The following is a description of a gene set: species: Mus musculus Mechanisms regulating self-renewal and cell fate decisions in mammalian stem cells are poorly understood. We determined global gene expression profiles for mouse and human hematopoietic stem cells and other stages of the hematopoietic hierarchy. Murine and human hematopoietic stem cells share a number of expressed gene products, which define key conserved regulatory pathways in this developmental system. Moreover, in the mouse, a portion of the genetic program of hematopoietic stem cells is shared with embryonic and neural stem cells. This overlapping set of gene products represents a molecular signature of stem cells. from publication Ivanova NB, Dimos JT, Schaniel C, Hackney JA, Moore KA, Lemischka IR (PMID 12228721) Mouse Gene Set: IVANOVA_HEMATOPOIESIS_LATE_PROGENITOR Genes in the expression cluster 'Late Progenitors Shared': up-regulated in hematopoietic late progenitor cells from adult bone marrow and fetal liver., and this is the list of marker genes: Pot1a, Atp6v1c1, Gm4870, Ccr2, Mtus1, Ppp4r3b, Mycbp (NCBI Gene Id 68249), Slc49a4, Qpctl, Rab31, Nsd3, Prkar2b, Ttc13, Trmt12, Car1, Ube2w, Baz1a, R3hcc1l, Wapl, Dok3, Klhdc2, C1qtnf12, Gpc1, Prelid3b, C330018D20Rik, Napg (N-ethylmaleimide sensitive fusion protein attachment protein gamma, NCBI Gene Id 71953), Sav1 (NCBI Gene Id 80625), Fdps, Tmem167, Sema4d, Tnfaip8l2, Sgms2, Ppp2cb, Pstpip2, Vps8, Pitpnb, Coa5, F13a1, Rfwd3, Hectd3, Rgcc, Cdc6, Rcc1, Xpnpep3, Soat1, Wee2, Tlk1, Gm12670, Wnt4, Adss2, Usf1, Stambpl1, Cdc25b, Lyrm9, Selenoi, Lman1 (lectin, mannose-binding, 1), Tango2, Apeh, Irf8, Mtfr1, Rhoa (NCBI Gene Id 51787), Dad1, Tmx4, Rarb, 1700029M20Rik, Slfn2, Slc38a5, Csnk1g3, Ehd2, G6pdx, Rab3c, Nfib, Oat, Tifa, Nxpe4, Fgl2, Gda, Lce3b, Smco3, Ugdh, Saa3, Skic8, Cetn3, App, Asap1, Seh1l, Cybb, Necap2, Wrn, Aldh1a7, Rnmt, Rnf115, Szrd1, Cisd1, Gdi2, Msmo1, Slc29a1, Sgk3, Bmp2k, Mrps36, Abr, Ccdc127, Rabgap1l, Gal3st2, Bsg, Rnf130 (ring finger protein 130), Acot9, Elovl7 (ELOVL fatty acid elongase 7), Pacsin2, Ipcef1, Ghitm, S1pr4, Nadsyn1, Mthfd1l, H1f5, Kctd7, Acp1, Ccdc102a, Prdx3, Psmc6 (NCBI Gene Id 67089), Mapk7, Abcb7, Anxa2, Dnajb3, Plekhf2, Il13ra1, Hp, 4931439C15Rik, Sdccag8, Pin1rt1, Harbi1, Meaf6, Map2k4, Tstd3, Garem1, Tmem19, Pus7l, Usp45, Synrg, D6Wsu163e, Rgs10, Fgfrl1, Ces2g, Sp6, Eno1, Nptn, Ms4a4b (NCBI Gene Id 60361), Tacstd2, Ifrd2, Cx3cr1, Klf1, Mrpl16, Ptgr1, Ncapg2, Katnbl1, Abcd2, Spire1, Trappc2l, Ufc1, Tyrobp, Twf2, Gak, Aldh3b2, Slc12a4, Gpn2, Hectd4, Ppp2r1b, Ero1a, Ltb4r1, Zbtb18, Chac1, Ly6c1, Ube2v2, Icam4, Rag1, Emc6, Nfu1, AI839979, Kcnq3, Mgl2, Tmed3, Rgs9, Plek, Cd33, Idh1, Zfp120, Atxn10 (NCBI Gene Id 97949), Smim45, Atrn, Ly86, Gm11992, Med7, Hmbs, Lefty1, Rab32, Map1a, Art2b, Pgp, Ftsj1, Sntb1, Fut4, Plin2, Ubxn2a, Hpf1, Hnrnpll, Ttc9c, Stx11, Mt2, Slc35a3 (NCBI Gene Id 70398), Sorl1, Gpr160, Dhx35, Gm40372, Ncoa4, Fcgr2b (NCBI Gene Id 98391), Sphk1, Acer3, Atf6, Arpc4, Nsdhl, Lpcat2, St7l, Dock10, Csgalnact2, Blvrb, Tada2b, Espl1, Alg8, Itga1, Adrm1, Atp6v0b, 1500015L24Rik, Casp1, Kti12 (KTI12 homolog, chromatin associated), Hcst, Btnl9, Kif1b, Ms4a6c, Nek3, Ap3s1, Napa, Tlr1, Slc35e1, Gmcl1, Exoc6, Agps, Tmem43, Pomk, Saxo2, Zmynd12, Klhl32, H2-DMb1, Bcl2l15, Tcstv2a, Tvp23b, Lamtor4, Glrx, Gsr, Mob3a, Cdc37l1, Fastkd2, Gga2, Mrpl50, Pitrm1, Kpna1, Zeb2, Ubap1, Slc25a33, Ms4a6b, AB124611, Plin5, Gm14270, Umad1, Nrp1, Tmem33, Dnmt3l, Ctss, Zcchc8, Eaf1, Cers6, Ankrd22, Csf2rb, Rnaseh2b, Cdc42, Ccr1, I830077J02Rik, Lin9, Prss16, Pbk, Tent5a, Map2k1, Ccdc88b, Rnf41, Eapp, Rab44, Mrps6, Osgepl1, Api5, Bag2, Clptm1l, Nup205, Abcb4, Ipmk, Tfrc, Pramel52-ps, Hvcn1, Tacc1, Neurl1a, Slc14a1, Usp14, Sap30, Fcgr1, Commd5, Nuf2, Tspan33 (NCBI Gene Id 71762), Alad, Pradc1, Gbe1, Tent5d, Eef1d, Mfsd14a, Apoo, Tasp1, Tk1, Dhx8, Map3k13, Srsf1, Spc25, Cdc123, Galnt10, Mtfp1, Hpse, Birc5, Sptlc2, Insig2, Tm9sf1, Slc25a21, Nucb2, Gtsf1, Orc4, Slc45a3, Eri1, Met (NCBI Gene Id 194383), Ube2q1, Xpo5, Ankrd46, G6pd2, Usp24, Slc25a51, Cep350, Rap1a, Bcap29, Atp9b, Dapl1, Aldh3a2, Fbxo33, Ggnbp2, Kcnj2, Atp6v0e, Ints4, Mapk1, Wdr7, Lta4h, Gpr101 (NCBI Gene Id 245424), Mt1, Dhrs7, Serbp1, Hadhb, Evi2a, Fam107b, Eif2s1 (NCBI Gene Id 76274), Hspbap1, Rbm44, Slc15a4, D430040L24Rik, Xrra1, Cd300a, Rab7, Cpox, Septin8, Cpne8, 1810059H22Rik, Alas1, Ctsc, Vma21, 2810408I11Rik, Prdm10, Mpeg1 (macrophage expressed gene 1), Havcr1, Dusp11, Rpe, Phf5a, Atad5, Oip5os1, Cisd2, Snx1 (sorting nexin 1), Usp46, Tmem165 (NCBI Gene Id 21982), Dap3, AI115009 (NCBI Gene Id 99542), Minpp1, 6030458C11Rik, Slc39a3, Ermap, F10, Asb1, Ormdl2, Igll1, Ctsg, Ankrd28, Cldn15, Adss1, Myo5c, Spring1, Cptp, Clint1, Uggt1, Troap, Ascc2, Rrm2, Fndc3b, Mastl, Rpain, Lrrc20, Spopl, Piezo1, Lamtor3, Mcts2, Mir223, Svip, Frs3os, Ostm1, Tmem50b, Ccnc, Slc22a4, Sat1, Slbp, Il1rl1, Gdf3, Ckap2l, Get3, Slpi, Ifi30, Ptpro, Lzic, AU019990, Fnip1, Mgam, Nin, Lrp8, Itpa, Gmip, Fignl1, Crybg2, Exoc5, Slc33a1, Smap1, Dffb, Tasl, Btla, Yae1d1, Lgals12, Pabir1, Etf1, Esco2, Lyst, Cenpp, Ndufv1, Gin1, Arrdc1, Abhd5, Cables2, Sell, Rfesd, Hck (NCBI Gene Id 99093), Slc31a2, Clp1, Pold1, Trex2 (three prime repair exonuclease 2), Gmps (NCBI Gene Id 229363), BC031181, Col5a1, Fth1, Cxadr, Phf10, Abca9, Gpr89, Ctsb, Ap1s2, Ptcd3, Mtx2, Tmem14c, Dram1, Mcm2 (minichromosome maintenance complex component 2), Ostf1 (osteoclast stimulating factor 1), Tmem216, Hdc (NCBI Gene Id 99319), Ankrd12, 2500002B13Rik, Urod, Tmed2, Emilin2, Dna2, Tmem248, Ccl9, Dera, Tmem156, L3mbtl2, Ttr, Ssh1, Reep1, Clec12a, Anxa3, Psmc1, Ap5m1, Cgn, Katnb1, Asf1b, 4930423M02Rik, Cdk5, Ext1, Gatc, Cemip2, Elmod1, Gpr135, Ubtd1, Kctd14, Lhfpl2, Ppil1, Cmtm2a (CKLF-like MARVEL transmembrane domain containing 2A), Hbs1l, Hsd11b1, Hcfc2, Btnl5-ps